The following is a description of a gene set: The process of activating or increasing the rate or extent of mesenchymal cell proliferation. Mesenchymal cells are loosely organized embryonic cells. species: Homo sapiens Human Gene Set: GOBP_POSITIVE_REGULATION_OF_MESENCHYMAL_CELL_PROLIFERATION, and this is the list of marker genes: FOXP2, SOX9, TGFBR2, SIX1, WNT2, TBX1, KDR, FGFR2, CHRD, FOXF1, IHH, SMO, FGF9, WNT5A, LRP5, PRRX1, CTNNB1, SHOX2 (NCBI Gene Id 6474), IRS2, MYC, BMPR1A, SHH, ARHGAP5, STAT1, MYCN, PDGFA, FGFR1